The following is a description of a gene set: studied in species Homo sapiens Any process that modulates the frequency, rate or extent of reactive oxygen species metabolic process. Human Gene Set: GOBP_REGULATION_OF_REACTIVE_OXYGEN_SPECIES_METABOLIC_PROCESS, and this is the list of marker genes: ACP5, ACOD1, SPHK2, SYK, BCO2, TP53, MIR27B, SLC25A33, SOD2, TRAP1, PRKN, PINK1, MIR181A2, BCR, PAGE4 (PAGE family member 4), DCXR, MIR21, BIRC2, RNF41, ABCD2, F2, EIF6, ABCB7, ROMO1, CCN6, MPV17L, RHOA, MAPK14, TFAP2A, NOXA1, DHRS4, FYN, DHFR, PIKFYVE, SLC5A3, STAT3, GCH1, COQ7, CFLAR (CASP8 and FADD like apoptosis regulator), RIPK3, CD177, GADD45A, CRP, APP, DHFRP1, PPARA, HDAC6, GSTP1, CYP1B1, PID1, MT3, DUOXA2, ATG5, ZC3H12A, SNCA, PON3, MIR24-1, TNF, BRCA1, TLR4, HP, FBLN5, VDAC1, MIR675, NFE2L2, MPV17, CLCN3, TIGAR, RAB27A, PRDX2, NNT, G6PD (glucose-6-phosphate dehydrogenase), AGT, PAX2, FOXO3, ZNF205, HVCN1, BMP7, ITGAM, PRCP, ARG2, SIRT2, ACE2, LEP, FAS, TLR6, THBS1, CLEC7A (NCBI Gene Id 64581), GRB2 (growth factor receptor bound protein 2), TSPO, RAC2, CDKN1A, ADGRB1, PLCG2, INS, AKR1C3, NOX5, ITGB2, AKR1C1, DUOXA1, LCN2, MYCN, NOXO1 (NCBI Gene Id 124056), CRYAB (crystallin alpha B), PARL, SHC1, CYBA, BST1, PARK7, SIRPA, FPR2, SLC18A2, TUSC2, SOD1, MAPT, MIR590, STK17A, TGFB1, IER3, SIRT3, RIPK1, MMP3, ADCY10, LRRK2, RAC1, GRIN1, PRKCD, SIRT5, FOXO1, NDUFC2, ALOX5, ARF4, F2RL1, TYROBP, AGTR1, CBR1, CD36, PLIN5, TGFBR2, GNAI2, ABCD1, ELAVL1, FOXM1, PDGFB, HK2, PDK3, PRKCE, UCP1, PDGFRB